The following is a description of a gene set: from publication Ghandhi SA, Yaghoubian B, Amundson SA (PMID 19108712) studied in species Homo sapiens Background: The existence of a radiation bystander effect, in which non-irradiated cells respond to signals from irradiated cells, is now well established. It raises concerns for the interpretation of risks arising from exposure to low doses of ionizing radiation. However, the regulatory mechanisms involved in the bystander response have not been well elucidated. To provide insight into the signaling pathways responding in bystanders, we have measured global gene expression four hours after bystander and direct alpha particle exposure of primary human lung fibroblasts. Results: Although common p53-regulated radiation response genes like CDKN1A were expressed at elevated levels in the directly exposed cultures, they showed little or no change in the bystanders. In contrast, genes regulated by NF_B, such as PTGS2 (cyclooxygenase-2), IL8 and BCL2A1, responded nearly identically in bystander and irradiated cells. This trend was substantiated by gene ontology and pathway analyses of the microarray data, which suggest that bystander cells mount a full NF_B response, but a muted or partial p53 response. In time-course analyses, quantitative real-time PCR measurements of CDKN1A showed the expected 4-hour peak of expression in irradiated but not bystander cells. In contrast, PTGS2, IL8 and BCL2A1 responded with two waves of expression in both bystander and directly irradiated cells, one peaking at half an hour and the other between four and six hours after irradiation. Conclusion: Two major transcriptional hubs that regulate the direct response to ionizing radiation are also implicated in regulation of the bystander response, but to dramatically different degrees. While activation of the p53 response pathway is minimal in bystander cells, the NF_B response is virtually identical in irradiated and bystander cells. This alteration in the balance of signaling is likely to lead to different outcomes in irradiated cells and their bystanders, perhaps leading to greater survival of bystanders and increased risk from any long-term damage they have sustained. Human Gene Set: GHANDHI_DIRECT_IRRADIATION_UP Genes significantly (FDR < 10%) up-regulated in IMR-90 cells (fibroblast) in response to direct irradiation., and this is the list of marker genes: DUSP2, OSBPL3, POLH, CXCL5 (C-X-C motif chemokine ligand 5), LRP8, THSD1, NAMPTP1, GPR68, MYPN, NEFM, RGS9, PTGFR, MMP1 (matrix metallopeptidase 1), PIDD1, CLDN1, PRDM1, CDKN1A, BTG3, MT1B, BIRC3, NFKBIZ (NFKB inhibitor zeta), MMP10, KYNU, HIP1, RRM2B (ribonucleotide reductase regulatory TP53 inducible subunit M2B), TRIAP1, MT1E, NPIPB13, RELB, MIR23AHG, PTGS2, LIF, MT1G, TESC, E2F7, CYP26B1, AEN, IL1A, LAMC2, NAMPT, IL6, OR11A1, TIGAR, POU5F1, TSLP, CXCL2, ANXA10, TNFRSF10B, INHBA, SLC16A6, GDNF, IL11, IL1B, MT1X, THBS1-IT1, C2CD4B, FRMD4A, BCL2A1, GDF15, SESN1, TCIM, PLCL2, GCH1, PLEK2, C3orf52, IL33, SLC30A1 (NCBI Gene Id 7779, solute carrier family 30 member 1), MYBL1, GPATCH2L, SMC5, BBC3, IFNE, VWCE, TNFAIP3, HSPA4L, GADD45A, ZC3H12C, MDM2, SOD2, TNFRSF10C, HSD11B1, ANKRD20A1, PTPRE, MT1H, SERPINB2, CXCL3 (NCBI Gene Id 2921), FAM20A, DKK1 (dickkopf WNT signaling pathway inhibitor 1), MMP3, LAMB3, MT2A, SLC7A11, IL12A, EYA3, G0S2, SLC16A6P1, CREB5, FAS, CXCL1, PPP6R1, CXCL8 (C-X-C motif chemokine ligand 8), ASCC3, BLOC1S2, FGF2, BMP2